The following is a description of a gene set: species: Homo sapiens from publication Chen Y, Wang X (PMID 31504780) Human Gene Set: MIR1182 Genes predicted to be targets of miRBase v22 microRNA hsa-miR-1182 in miRDB v6.0 with MirTarget v4 prediction scores > 80 (high confidence targets)., and this is the list of marker genes: MAP1LC3B, PIP4K2A, LCN10 (NCBI Gene Id 414332), MED1, PKIA, RELN, MYO5C, YTHDF1, THBS3, ANKLE1, ZNF609, NPSR1, ABCC12, GPR176, HSPB6, C14orf28, EIF4ENIF1, UVRAG, AMMECR1 (NCBI Gene Id 9949), SF3A3, TCP11L2, EBF3, AMIGO2, ANKRD66, SNTG1, DCLK1, ANPEP, ARID1A, TBX5, OLA1 (Obg like ATPase 1)